The following is a description of a gene set: Mouse Gene Set: HEVNER_CORTEX_S_PHASE Genes selectively expressed by proliferating cells during S phase of the cell cycle in embryonic day 14.5 mouse cortex. from publication Bedogni F, Hevner RF (PMID 34321999) species: Mus musculus, and this is the list of marker genes: Cdc45, H1f2, Wdhd1, Mxd3, Skp2, Ccnf